Given this list of marker genes NFXL1, CDH22, PARP3, FOXP2, IL18BP, SLFN12L, PARP11, IL6, VGLL4, ATP6V0A2, NHSL1, PUS10, DOCK8, TLR8, SPRY2, ENG, TCEANC2, NMI, ARHGAP11A, GBP4, RIN2, TAPBPL, FOS, CPT1A (NCBI Gene Id 1374), ZNF141, CHST1, SLFN5, POP4, MAX, GRIK2 (glutamate ionotropic receptor kainate type subunit 2), ZBP1, MSRB2, BST2, ZNF213, RGMB, STARD3NL, FEM1C, L3MBTL3, FNDC3A, IKZF2, MORC3 (MORC family CW-type zinc finger 3), TLR5, ADAR, PPIP5K2, KAT2B, TAOK3, RAB9A (NCBI Gene Id 9367), CSF1, CAB39L, CRIM1, SMOX, ALLC, BMAL1 (basic helix-loop-helix ARNT like 1), SERTAD1, MISP, IFT172, ENTPD6, TOMM70, FGL2, KYAT3, OGFR (opioid growth factor receptor), PLOD3, TMEM243, GBP7, DBR1, ZNF513, MCMBP, GCNT2, PAG1, NABP1, RBL1, NFIL3, PKIB, CCIN (calicin), SIRT3, SLAMF7, MTA3 (NCBI Gene Id 731342), PNLIP, NKIRAS1, ATP8B2, AREL1, UBE2E1, PLEKHN1, LRCH3, TREML2, NUDT9, ATF3, FAM53C, PRKX, OAS3, IL18, PRNP, PLPPR3, LARP1, USP42, MB21D2, DDX24, URGCP (upregulator of cell proliferation), BCO2, TIPARP, PLAAT3, GSDMD, TNFSF8, TRPM1, ISY1, NAMPT, MARVELD2, ISG20, BRME1, ENPP4, XRN2, PARP8, DAPL1, FLT3LG, SIGMAR1, ITPK1, PPHLN1, SYNJ1, PLEKHA3, UACA, NSMCE1, CWC22, PIK3AP1, TRIM5, NLRC5, PPFIA4, DDX60, TRIM56, FAM217B, NSD3, CDS1, TOR1AIP2, PARP12, NDST2 (NCBI Gene Id 8509), IL10RA, COL5A3, HMOX2, FCGR3A, ZBTB5, TAL1, SRGAP2, INPP1, SLC35F5, AP3M2, NDRG4, PIGV, TCF4, ASCC3, PDE7A, ARID4A, CHMP5, SOCS2, NIPA2, USP25, CRLF3, NSMAF, CD180, TIAM1, ANKLE2, KEAP1, MARCHF5, SDAD1, DIPK1A, POLB, PLA2G4A, RASA4, ETV6, PSMA4, IL4R, PROS1, C14orf93, AMER1, CASP7 (NCBI Gene Id 840), INTS9, GPT2, SLC30A1, LGALS3BP, ZC2HC1A, CARD6 (NCBI Gene Id 84674), CHRNA5, UVRAG, RASA3, MINPP1, CASP12, SESN3, ETV1, ARF4, CHMP4B, SFRP1 (secreted frizzled related protein 1), WRN, CASP1, RGL1, COA5, PMFBP1, OSM, GPR108, TDRD7, CERS6, NAP1L2, KIAA0040, here is a description of the gene set: Human Gene Set: GSE36009_WT_VS_NLRP10_KO_DC_UP Genes up-regulated in dendritic cells: wildtype versus NLRP10 knockout. species: Homo sapiens from publication Eisenbarth SC, Williams A, Colegio OR, Meng H, Strowig T, Rongvaux A, Henao-Mejia J, Thaiss CA, Joly S, Gonzalez DG, Xu L, Zenewicz LA, Haberman AM, Elinav E, Kleinstein SH, Sutterwala FS, Flavell RA (PMID 22538615) Nlrp10-deficient mice have a profound defect in helper T cell-driven immune responses. T cell priming is impaired due to a defect in the emigration of a dendritic cells from inflamed tissue and antigen transport to draining lymph nodes. DC chemotaxis to CCR7-dependent and independent ligands is intact in the absence of Nlrp10. Therefore to identify novel molecules potentially involved in Nlrp10-dependent DC function we used an unbiased gene array approach on Nlrp10-deficient BMDCs treated with or without LPS.